The following is a description of a gene set: studied in species Homo sapiens Creatine pathway. Pathway ID: N01612. Pathway type: Reference. Pathway class: nt06033 Glycine, serine and arginine metabolism. Human Gene Set: KEGG_MEDICUS_REFERENCE_CREATINE_PATHWAY Pathway Definition from KEGG: Arg+Gly -- GATM >> GAMT -> Cr -- CK -> Crn, and this is the list of marker genes: GATM, GAMT, CKM, CKMT2, CKMT1A, CKMT1B, CKB